The following is a description of a gene set: species: Homo sapiens Human Gene Set: GSE3982_CTRL_VS_LPS_4H_MAC_DN from publication Jeffrey KL, Brummer T, Rolph MS, Liu SM, Callejas NA, Grumont RJ, Gillieron C, Mackay F, Grey S, Camps M, Rommel C, Gerondakis SD, Mackay CR (PMID 16474395) In the present study we used Affymetrix oligonucleotide microarrays to produce gene transcription profiles for the major leukocyte types in humans. This comprehensive dataset enabled us to not only establish which genes were expressed in each leukocyte type, but also which genes were expressed in each subset after activation. The used of a comprehensive dataset of gene profiles from all the major human leukocyte subsets enabled a novel and powerful means for identification of genes associated with single leukocyte subsets, or different immune paradigms. Genes down-regulated in comparison of untreated macrophages versus macrophages treated with LPS (TLR4 agonist) at 4 h., and this is the list of marker genes: NLE1, CD80, LRP12, GPR132, IFIT2, DEK, TLR7, PIK3R5, RPS6KC1, PITPNA (NCBI Gene Id 5306), TBC1D9, HERC5 (HECT and RLD domain containing E3 ubiquitin protein ligase 5), DENND1A, NADK, CCL5, SIAH2, TUBB6, GADD45B, IFIT5, EIF1B, ARL8B, TRIM25 (tripartite motif containing 25), LYZ, TFEB, NECTIN2, IFI16, EXOC5, CASP7, SLC7A10, RASA3, CYB5A, IL23A (interleukin 23 subunit alpha), ARID5B (AT-rich interaction domain 5B), SP100, PGK1, CKB, JAG1, MTHFD2, GNAI3, BACH1, HIPK3, SASH1, TMX1, BTG3, CDC73, CYP1A1, KANSL1L, SFPQ, EZR, TRABD, KCNA1, SLC6A11, SLCO4A1, PDZRN4, ROCK2, BLVRA, SAR1A, PLEK, CCR4, STK26, FAP, MMP1, DCP1A, DENND5A, NDEL1, MFHAS1 (NCBI Gene Id 9258), ELK4, KCNE4, DDX6, FKBP10 (NCBI Gene Id 60681), IFITM1, KCNA3, BIRC2, UBE2E1, AMPH, STAT1, RAB33A, CD55, MAFF, AGRN (NCBI Gene Id 389836), EWSR1, GAB2, BCL2L1, CCSER2, NDST3, TDRD7, MYD88, USP18, ZBTB38, CSRNP2, BASP1, CHST11, CMA1, OAS1, ERP44, TARP, FUT4, TICAM1, OASL, KDM6A, HSD11B1, SPSB1, CD40, COX17, ITGB8, HSPBAP1, RCAN1, ADAR, IFI44L, APOBEC3G, SLAMF1, ZFX, IL10RA, F2RL1, DYRK3, IL36G, PMAIP1, KLF6, NUP62, IRF8, MT1F, CD99, MTMR9, CFLAR, NEK7 (NCBI Gene Id 148565), CEBPD, LAMP3, APOL1, BAK1, MME, NFKB2, PPFIA2, IFI35, HIVEP2, TIA1, NUPR1, MT1X, ISG20, HIF1A, USP15, SLC1A2, GABPB1, IFI44, SEMA3C, FAS, STAT2, DAPP1, ZC3H12A, MYOD1, PDE4B, IRF1, IRF2, NECAP2, TRAF1, WAPL, ELF4, CCR5, CLIC4, FAM13C, ATP13A3, HCAR3, LYVE1, CHMP5, WARS1, TIPARP, PSMB9, IL1RN, USP12, PPM1E, CREB1, LIG4, PRPF3, BAZ1A, CD48, KMO, RAB2A, STK10, NBN, RRBP1, SNTG2, RUNX3, TNFAIP3, ABL2, IFIH1, TRAF4, HOXC6, HNRNPC, CD38, TFR2, SPHK1, MIIP, SPRED2, RBCK1, GOLGA4, CAV1, SP140L, CCNA1, REL, PLAGL2